Given this list of marker genes Gpt, Eno3, Zbtb17, Aebp1, Col1a2, 1700001F09Rik, Deaf1, Plekha5, Ccl21a, Hoxa7, Cd247, Thrsp, Gmpr, Gm3143, Apoc1 (NCBI Gene Id 11812), Doc2g, Mxra8, Ccl27a, Acsbg1, Col1a1, Ankrd17, Grn, Ccdc28b, Sh3glb2, Tmem255a, Itm2b, Tcap, Rsrp1, here is a description of the gene set: studied in species Mus musculus Mouse Gene Set: SCHLINGEMANN_SKIN_CARCINOGENESIS_TPA_DN Malignant transformation of mouse skin by chemical carcinogens and tumour promoters, such as the phorbol ester 12-O-tetradecanoylphorbol-13-acetate (TPA), is a multistage process that leads to squamous cell carcinoma (SCC) formation. In an effort to identify tumour-associated genes, we studied the influence of short-term TPA-treatment on the gene expression profile of murine skin. A comprehensive microarray with some 5,000 murine gene specific cDNA fragments was established and hybridised with pooled RNA derived from control and TPA-treated dorsal skin samples. Of these genes, 54 were up- and 35 were down-regulated upon TPA application. Additionally, we performed suppression subtractive hybridisation (SSH) with respective RNA pools to generate and analyse a cDNA library enriched for TPA-inducible genes. Expression data of selected genes were confirmed by quantitative real-time PCR and Northern blot analysis. Comparison of microarray and SSH data revealed that 26% of up-regulated genes identified by expression profiling matched with those present in the SSH library. Besides numerous known genes, we identified a large set of unknown cDNAs that represent previously unrecognised TPA-regulated genes in murine skin with potential function in tumour promotion. Additionally, some TPA-induced genes, such as Sprr1A, Saa3, JunB, Il4ralpha, Gp38, RalGDS and Slpi exhibit high basal level in advanced stages of skin carcinogenesis, suggesting that at least a subgroup of the identified TPA-regulated genes may contribute to tumour progression and metastasis. from publication Schlingemann J, Hess J, Wrobel G, Breitenbach U, Gebhardt C, Steinlein P, Kramer H, Fürstenberger G, Hahn M, Angel P, Lichter P (PMID 12640676) Down-regulated in murine dorsal skin cells at 6 h after treatment with the phorbol ester carcinogen TPA.